Given this list of marker genes ALAD, UROD, UROS (NCBI Gene Id 7390), GATA1, CPOX, here is a description of the gene set: Increased fecal porphyrin Human Gene Set: HP_INCREASED_FECAL_PORPHYRIN studied in species Homo sapiens Abnormally high concentration of fecal porphyrins in feces.